The following is a description of a gene set: Human Gene Set: HP_ACANTHOLYSIS species: Homo sapiens Acantholysis The loss of intercellular connections, such as desmosomes, resulting in loss of cohesion between keratinocytes., and this is the list of marker genes: ATP2A2, KRT2, JUP, IKZF1, HLA-B, ATP2C1, CAST, TUFT1, DSG1, DSP